Given this list of marker genes COG3, TOX, CAAP1, CELSR1, ZNF445, OLFM2, B4GALT4, AHR, ANKH, ARHGAP5, ZDHHC23, LDLRAD4, QKI, FBLN2, MDFIC, KLHL24, VSIR, CDK17, GLCCI1, COQ10B, CNST, CDH1, ATP1B3, GOLIM4, GNGT2, HIVEP2, SLC4A5, DIP2B, C3orf80, DEXI, SLC4A10, SFRP2, STMN3, MATN4, RAB3IP, PLEKHA1, SPECC1, TGFB3, TIPARP, SOX1, DCLRE1B, RC3H2, CADM1, SERPINI1, RGS2, WDR13, ADAMTS6, CPD, SHC3, SMYD3, ZNF740, RNASE6, TMEM127, RAB11FIP2, CSPG4, GNA12, RYR2, QPRT, FBXO30, BAIAP3, NT5E, C8orf33, RTP3, USP26, GCNT1, TNKS, STX16, TRMT10A (NCBI Gene Id 93587), SMURF2, PAPOLB, MDGA2, SBK1, TTC17, USP32, MEGF10, PLEKHH1, TTC39B, B4GALNT4, CDHR2, DNAJA4, TMX4, KIAA1958, RIPOR2, KPNA4, CA2, TDRKH, FNDC3A, SLA2, KCNB1, ZBTB37, SPTA1, LITAF, AGTR2, OLFML3 (olfactomedin like 3), ACVR1B, PROS1, CREBBP, ZNF644, ARHGAP39, VANGL1, IGFLR1, LGALS3BP, MOB1B, IRX3, HSD11B1, TLR7, KLHL25, FAM234B, MTMR3 (myotubularin related protein 3), RNF149, NAAA, NEO1, STX2, LRIG1, RNF152, PLEKHM3, MELTF, PARP12, PLCXD2, SUGCT, GRIA3, AOAH (acyloxyacyl hydrolase), CACUL1, POU6F1, C2CD3, ATP6V1C2, ZBTB18, ITGA2, CERS6, PACSIN1, ELAVL4, CIMIP6, GPR171, CHMP1B, PRICKLE1, ABCA1, FOXP3, RANBP6, IFITM3, SPSB1, TNFRSF13C, CD8A, SKIL, NTNG1, FCHSD2, TMPRSS11F, MAX, SELENOT, GPR15, COLEC10, TRIO (NCBI Gene Id 7204), BPNT2, APOA5, PPM1H, C8orf82, GLRB, SUN2, SS18L1, WDR54, TP63, FUBP3, HID1, FOXO1, ITPR1, ARFGEF1, ELK3, CD40, CLNK, IKZF4, KIAA0232, MYO9A, FAM170B, TNFRSF1B, OAS1, MED10, PRNP, DTNBP1, TBPL1, PHLPP2, PLAC9, MMP11, IGFBP4 (NCBI Gene Id 3487), WNT5B, ANKRD50, SNRK, ACVR2A, LACTBL1, ZCCHC2 (NCBI Gene Id 84810), FERD3L, TMEM50B, RAC3, SLC26A8, GPR34, ARIH2 (ariadne RBR E3 ubiquitin protein ligase 2), MAF, BTRC, TBC1D23 (TBC1 domain family member 23), TIMP2, MGAT4A, MOSMO, here is a description of the gene set: Genes down-regulated in comparsion of ActCD8 versus ActCD8TGF (see Fig. 1 in the paper for details). Human Gene Set: GSE7460_CTRL_VS_TGFB_TREATED_ACT_CD8_TCELL_DN studied in species Homo sapiens The transcription factor Foxp3 is usually considered the master regulator for the CD4+CD25+ from publication Hill JA, Feuerer M, Tash K, Haxhinasto S, Perez J, Melamed R, Mathis D, Benoist C (PMID 18024188)